The following is a description of a gene set: electronically inferred by orthology from the curated human pathway part of: Platelet activation, signaling and aggregation studied in species Mus musculus Reactome Pathway: Response to elevated platelet cytosolic Ca2+ This event has been computationally inferred from an event that has been demonstrated in another species.<p>The inference is based on the homology mapping from PANTHER. Briefly, reactions for which all involved PhysicalEntities (in input, output and catalyst) have a mapped orthologue/paralogue (for complexes at least 75% of components must have a mapping) are inferred to the other species., and this is the list of marker genes: Tuba4a, Serping1, Spp2, Tmsb4x, Igf2, Mmrn1, Fgg, Apoh, Tln1, Cd36, Pf4, Gas6, Lhfpl2, Tgfb1, Psap, Tex264, Brpf3, Cd9, F8, Fam3c, Lgals3bp, Apoa1, Orm1, A2m, F13a1, Chid1, Timp1, Cdc37l1, Cfd, Orm2, Stx4a, Itih4, Hgf, Rarres2, Ly6g6f, Pros1, Abcc4, Sytl4, Aplp2, Pdgfb, Itga2b, Vegfc, Pcyox1l, Trf, Alb, Serpinf2, Hrg, Vegfb, Pdgfa, Tmx3, Itih3, Selp, Ctsw, Lamp2, Plg, Maged2, Stxbp3, Rab27b, Ahsg, Kng2, Prkcg, Islr, Gtpbp2, Vegfd, Cd109, Vegfa, Pcdh7, Calm1, Scg3, Aldoa, Nhlrc2, Srgn, Prkca, Sparc, Tor4a